Given this list of marker genes SYT17, NRXN2, TPO, CACNA1D, PPP1R3C, ACOT11, TNMD, AKAP4, SLIT3, LENEP, TUT1 (NCBI Gene Id 64852), ADARB2, MC1R, MSMB, ZNF407, PCSK1N, RAP1GAP, KRT17, CA5B, APOA1, CYP2D6, NDRG2, EIF4B, RPL4, RPS4X, LAMA2, TULP1, B4GALNT1, BMP2, MAST4, TSKU, CDX1, PTH1R, C22orf46P, ALDOAP2, SYNJ2, GABRB2, UBE2D4, SMOX, PLA2G2D, IL25, DNASE1L3, C1orf21, LGALS14, APOH, PTP4A3, FHL1, RGS16, UBE2O, DCTPP1, TAF4B, KCNC1, MYOM1, NBL1, CNNM4, SLC22A17, EEF1A2, PABPC4, LMAN1L, PGAP3 (post-GPI attachment to proteins phospholipase 3, NCBI Gene Id 93210), TBC1D29P (NCBI Gene Id 26083), KYAT1, CTSF, SUV39H1, CSN3, ERC2-IT1, HSPB7, ABCA12, GIP, LRRC2, NEBL, NCAM1, HYI, IL22RA1, PCDHB12, CELSR1, PIWIL2, CD1C, GJB4, AGXT, ODAM (NCBI Gene Id 54959), CASR, LDB2, ZNF14, PLEKHG6, P3H4, TMEM177, RPLP0, NTN1, CTSE, CETP, SLC25A6, NEK11 (NIMA related kinase 11), APOB, ASPN, KHDRBS3 (KH RNA binding domain containing, signal transduction associated 3), C22orf31, RPS3A, NPPB, PTGDR2 (NCBI Gene Id 9484), LIPG, SPAG8, CAPN11, GNAT1, GFAP, FAM86C1P, WNT3, CALCB (NCBI Gene Id 797), FCER1A, IL2, SEPTIN11, SLC1A2, TM7SF2, NPAS2, FLG, PHF7, HOXD9, GDF3, MLEC, CRIP2 (cysteine rich protein 2), JPH3, CYP4F11 (NCBI Gene Id 57834), NTRK1, BRINP1, IMPG2, KRT6B (keratin 6B), GFRA3, GEM, SOX14, JMJD4, KRT33B (NCBI Gene Id 3884), LRRC36, RPL12 (NCBI Gene Id 90679), ABCA4, F2RL2, RAB30, AMBRA1, NR0B1, TUBA4B, CYP2J2, CDH8, SPAG6, RAB6B, CADM3, OCA2, SLC17A9, NLE1, TRMT61A, COL13A1 (collagen type XIII alpha 1 chain), CCT4, HLCS, SPRR2C, GH1, ACADL, IL37, SIRT4, CUZD1, DRP2, PRDM12, ARTN, KRT18, REPIN1, RNFT2, HYAL1, IQSEC3, RASSF9 (NCBI Gene Id 9182), KLHL3, COL10A1, NXPE4, OCRL, MAST2, DLG2, RHOF, HRC, ZNF85, STK16, MTUS2, FGD1, CYP4A11, SRPX2, CAD, LUZP2, RAD54L, KLK7, SARM1, NES, WDR4, KCNJ9, GPD1, SERPINB13, RAB11FIP3, CDCP1, TYRP1, LYRM9 (NCBI Gene Id 201229), ARHGAP6 (NCBI Gene Id 395), ABCB4, here is a description of the gene set: Genes up-regulated in comparison of healthy myeloid cells versus systemic lupus erythematosus myeloid cells. Human Gene Set: GSE10325_MYELOID_VS_LUPUS_MYELOID_UP from publication Hutcheson J, Scatizzi JC, Siddiqui AM, Haines GK 3rd, Wu T, Li QZ, Davis LS, Mohan C, Perlman H (PMID 18275831) Gene expression profile studies have identified an interferon signature in whole blood or mononuclear cell samples from patients with systemic lupus erythematosus. This study was designed to determine whether specific lymphocyte and myeloid subsets freshly isolated from the blood of systemic lupus erythematosus patients demonstrated unique gene expression profiles compared to subsets isolated from healthy controls. studied in species Homo sapiens